Given this list of marker genes Tcea3, Rabac1, Cpn1, Fhit, Nelfa, Lin54, Mki67, Nol9, Gm5817, Ddx54, Llph, Psd, Plekhg2, Arid1a, Abhd8, Gnao1, Svop, BC006965, Thbs4, Ezh2, Id1, Matcap1, Arhgef10l, Qtrt1, Atxn7l3b, Vps18, Frs3, Ccar1, Arhgap28, Hmgn1, Cdyl2, Clk2, Kcp, Plekha7, Grp (gastrin releasing peptide), Daglb, Kpnb1, Elavl1, Gtf2e1, Tgfb2, Kynu, here is a description of the gene set: species: Mus musculus The molecular mechanism responsible for a decline of stem cell functioning after replicative stress remains unknown. We used mouse embryonic fibroblasts (MEFs) and hematopoietic stem cells (HSCs) to identify genes involved in the process of cellular aging. In proliferating and senescent MEFs one of the most differentially expressed transcripts was Enhancer of zeste homolog 2 (Ezh2), a Polycomb group protein (PcG) involved in histone methylation and deacetylation. Retroviral overexpression of Ezh2 in MEFs resulted in bypassing of the senescence program. More importantly, whereas normal HSCs were rapidly exhausted after serial transplantations, overexpression of Ezh2 completely conserved long-term repopulating potential. Animals that were reconstituted with 3 times serially transplanted control bone marrow cells all died due to hematopoietic failure. In contrast, similarly transplanted Ezh2-overexpressing stem cells restored stem cell quality to normal levels. In a genetic genomics screen, we identified novel putative Ezh2 target or partner stem cell genes that are associated with chromatin modification. Our data suggest that stabilization of the chromatin structure preserves HSC potential after replicative stress. Mouse Gene Set: KAMMINGA_SENESCENCE from publication Kamminga LM, Bystrykh LV, de Boer A, Houwer S, Douma J, Weersing E, Dontje B, de Haan G (PMID 16293602) Genes down-regulated on serial passage of MEF cells (embryonic fibroblast).